The following is a description of a gene set: The regrowth of neuronal processes such as axons or dendrites in response to their loss or damage. species: Homo sapiens Human Gene Set: GOBP_NEURON_PROJECTION_REGENERATION, and this is the list of marker genes: BCL2 (BCL2 apoptosis regulator), MTR, KREMEN1, FIGNL2, DHFR, PUM2, MAPK8IP3, MIR221, STK24, CERS2, RTN4RL2, GRN, LAMB2, MMP2, DHFRP1, PTN, ULK1, NTRK3, JUN, CNTF, THY1, NREP, RTN4R, LRIG2, DAG1, INPP5F, PRRX1 (paired related homeobox 1), KIAA0319, JAK2, PTPRS, MIR222, APOD, GFAP (NCBI Gene Id 2670), RGMA, ADAM17 (NCBI Gene Id 6868), SCARF1, MIR431, OMG, TNC, PTPRF, APOA4 (NCBI Gene Id 337), TSPO, MAP1B, MAG, ISL1, MAP2K2, TNR, MATN2, RTCA, EPHA4, GAP43, SPP1, RTN4RL1, NEO1, MAP2K1, CTNNA1, BRAF, NEFL, KLF4, FOLR1